The following is a description of a gene set: Cytokines mediate cell-cell communication in the immune system and represent important therapeutic targets. A myriad of studies have highlighted their central role in immune function, yet we lack a global view of the cellular responses of each immune cell type to each cytokine. To address this gap, the authors created the Immune Dictionary, a compendium of single-cell transcriptomic profiles of more than 17 immune cell types in response to each of 86 cytokines (>1,400 cytokine-cell type combinations) in mouse lymph nodes in vivo. A cytokine-centric view of the dictionary revealed that most cytokines induce highly cell-type-specific responses. For example, the inflammatory cytokine interleukin-1β induces distinct gene programmes in almost every cell type. A cell-type-centric view of the dictionary identified more than 66 cytokine-driven cellular polarization states across immune cell types, including previously uncharacterized states such as an interleukin-18-induced polyfunctional natural killer cell state. Genes positively differentially expressed in cell type: Mast cell upon treatment with cytokine: GM-CSF in mouse lymph nodes in vivo. from publication Cui A, Huang T, Li S, Ma A, Pérez JL, Sander C, Keskin DB, Wu CJ, Fraenkel E, Hacohen N (PMID 38057668) studied in species Mus musculus Mouse Gene Set: CUI_MAST_CELL_GM_CSF_RESPONSE_UP, and this is the list of marker genes: Sergef, Isoc2b, Prpf18, Aldh3a2, Rfx1, Preb, Nudt2, Gpr141, Klhl28, Ccdc66, Mief1, Extl2, Polr2b (NCBI Gene Id 231329)